Given this list of marker genes EVA1A, SLC17A1, SLFN12, PRNP, IFI35, H2AC25, PSTPIP2, SLC2A10, IL17RA, LHX2, IKZF4, FKBP15, MCUB, S100A4, GPX3, ELAVL1, ASB11, CD86, ABCB9, RBM14, PLPP3, SEH1L (NCBI Gene Id 81929), PLAT, CTNNB1, USHBP1, LTA, YJU2B, MYL6, PLEKHO2, LITAF, P2RX5 (NCBI Gene Id 5026), NIBAN2, NAA20, FANCA, RPP25, CSF3R (colony stimulating factor 3 receptor), BATF3, FOXD4L1 (forkhead box D4 like 1), SEC24B (SEC24 homolog B, COPII coat complex component), RAB12, OPTC, HDAC1, ZFP14, CD300LF, CD84, CTTN, BATF2, ZDHHC20, KDR, SAAL1, ANPEP, PPP2R2A, TLR3, CPT1A, NT5C3A, GTF2F1 (general transcription factor IIF subunit 1), SBDS, MINK1, PPP1R18, ZNF235, PRPF38A, IQGAP1, CPSF7, TRPT1, EIF1AY, CHML, SLC25A29, CDYL, CISH, CD164, MET, SLCO1B3 (NCBI Gene Id 28234), PRKX, EIF4E3, SP110 (SP110 nuclear body protein), SEMA4D, FABP3, PARP9, DLX1, IL36A, ECHDC2, PSAT1, AP2B1, HMGN5, RPS6KC1, USP25 (ubiquitin specific peptidase 25), NIPSNAP3A, APOE, PTPN1, VRK1, EPGN, HOMER3, HOXA5, AIDA, JAG1, GDNF, MYO1F, RAP1B, ATP12A, SVEP1, LRRC8A, MEN1, CLEC7A, PLA2G2C (phospholipase A2 group IIC), RAB33A, SGK1 (NCBI Gene Id 6446), AP3M2, ZFYVE27, RTKN2, P2RX4, PML, THY1, HYI, ECE2, ABCG2, NCK2, NUP62, SAMHD1, SH3BGRL, MDM2, IL4I1, PTPN9, ALDH1B1, STAU2, SMG8, RMC1, RPS6KA3, ENDOD1, DBNL, MYL10, PCDH7 (NCBI Gene Id 90855), SAMD8, CAMLG, KLF10, PAPSS1, ATP8B2, ZUP1, CIITA, CCL4 (NCBI Gene Id 6351), MCM10, IRF7, NECAP2, JPT1, TMEM50B, SUN2, IL6ST (NCBI Gene Id 3572), ESYT1, IFI27L2, VRK2, GPSM2, UBA7, KCNAB1, INPP5A, CBLN1, PMEPA1, ZFP30, ZFP36, ARL2, CAPN15, RBMS1, P2RY14, PKP1, HGSNAT, L1CAM, FURIN, IRX4, NCOA3, ASB13, ICOSLG, NFKB1, ANP32E, SPHK1, SLC6A8, TSC22D1 (TSC22 domain family member 1), NUSAP1, TTL, IL15RA, ALAS1, CRYBA1, IL1B, GJB4, TMEM106A, SLAMF8, MOV10, PGPEP1, UCN, RDM1, FAM89B, TGFB1, DOK1 (NCBI Gene Id 1796), FNBP4, EVL, PKMYT1, PRG3, HMBOX1, ANGEL2, GPR84, IGF2BP3, CD40, here is a description of the gene set: mouse primary BMDCs were stimulated with tlr ligands and gene expression changes were profiled on Affymetrix arrays Genes up-regulated in comparison of dendritic cells (DC) stimulated with Gardiquimod (TLR7 agonist) at 12 h versus those stimulated with Gardiquimod (TLR7 agonist) at 24 h. from publication Amit I, Garber M, Chevrier N, Leite AP, Donner Y, Eisenhaure T, Guttman M, Grenier JK, Li W, Zuk O, Schubert LA, Birditt B, Shay T, Goren A, Zhang X, Smith Z, Deering R, McDonald RC, Cabili M, Bernstein BE, Rinn JL, Meissner A, Root DE, Hacohen N, Regev A (PMID 19729616) Human Gene Set: GSE17721_12H_VS_24H_GARDIQUIMOD_BMDC_UP studied in species Homo sapiens